The following is a description of a gene set: studied in species Homo sapiens Binding to a U2 small nuclear RNA (U2 snRNA). Human Gene Set: GOMF_U2_SNRNA_BINDING, and this is the list of marker genes: RO60, ISG20 (interferon stimulated exonuclease gene 20), COIL, SF3B3, SNRPA1, PRPF8